Given this list of marker genes PSMD6, PSMA5, PSMA4, PSMC1, PSMD8, GSK3B, PSMC3, PSMB2, PSMA3, PSMD11, PSMD14, PSMB4, PSMB7, CDK4, UBB, PSMD13, PSMA1, PSMC6, PSMB5, PSMA7, PSMD3, CCND1, PSMD12, PSMD2, PSMD7, PSMA2, PSMB6, RPS27A, PSMA6 (proteasome 20S subunit alpha 6), SEM1, PSMC2, PSMD1, PSMC4, PSMB3, UBA52, PSMB1, UBC (ubiquitin C), PSMC5, ADRM1, here is a description of the gene set: Cyclin D turnover is regulated by ubiquitination and proteasomal degradation which are positively regulated by cyclin D phosphorylation on threonine-286.<p>After the Cyclin D serves the role of mediating reactions by Cdk4 and Cdk6, it is shuttled to the cytoplasm and degraded in a ubiquitin-dependent manner. Whether Cdk4 and Cdk6 are truly redundant is a topic still under investigation, although both the kinases are required for normal cell cycle progression.<p>Destruction of the D type cyclins accompanies the end of the G1 phase, and the E type cyclins are involved in transition of the cell from G1 to S phase. Reactome Pathway: Ubiquitin-dependent degradation of Cyclin D part of: S Phase species: Homo sapiens